The following is a description of a gene set: species: Homo sapiens Genes having at least one occurrence of the motif SNNGATNNNN in the regions spanning 4 kb centered on their transcription starting sites. This matches the GATA1 transcription factor binding site V$GATA1_01 (v7.4 TRANSFAC). Human Gene Set: GATA1_01, and this is the list of marker genes: MMEL1, TLN1, GABRA3, PPP2R2A, ZNF516-DT, CNOT3, ARRDC1-AS1, XRCC6, HCRT, SNCA (NCBI Gene Id 6622), DYRK1A, SP7, HOXB5, STX1B, DLG2, CARMIL3, TSPAN1, ZIC1 (NCBI Gene Id 7545), KIF1B, YWHAE, CACNG2, ERG28, PTK7, ELAVL2, HR, HOXA10, HOXD10, NAB2, TF, SDHAF2, CREB3, OXCT1, PPP2R2B (NCBI Gene Id 56686), CLU, GRIN3A, SUV39H1, IL17B, SLC4A3, MAK16, ACACA, AZIN1, C6orf62, SCML4, RERE, NELFB, SOX2, BAHD1, HIRA, PROX1, ATP2B2, RAB3C, NDUFAF3, CDC27, FHL3, WAC, MED26, TNXB, TOR1AIP1, RSF1, ABRAXAS2, TNPO3, TTC9B, ENSG00000204117, FRMD5, CCDC140, ING3, BMP7, CLVS1 (NCBI Gene Id 157807), JOSD2 (Josephin domain containing 2), MRPL40, CLTA, LSAMP, PCDH8, YARS1, IL17RE, HSPA14, PRDX5, FEZF2, IL21, RAPGEF6, PTCHD1, ZIC4 (NCBI Gene Id 84107), PMS2P5, MAPRE3, SYNCRIP, BLCAP, GNB1, SRSF6, HSPG2, KIF3B, ACLY, KPNB1, HHEX, UBE2D2, PENK, DPYSL2, NFYC, TRERF1, CPSF7, KCTD13, RARG, ACTN3, NR2E1, SIPA1, ANK3, SLC39A5, SLAIN1, TLE3, GRID2, FAM181B, SPACA6 (NCBI Gene Id 730718), SLC8A3, BNC2, RCN2, TMEM196, RASAL2, PHEX, ZFHX3, TCF7L1, TSPAN5, VCPKMT, AAMDC, NHLH2, INHA, DHX15, CXCR5, GDF6, KAT7, MOSMO (NCBI Gene Id 730593), SREBF2, AMMECR1, ZNF423, SPOP, SUFU, PYGO2, RPS6KB1, SRF, AKT2, MAML3, EPHB1, ARL5B, NFIA, ATXN7L2, ENPP2, ANKRD17 (NCBI Gene Id 84177), PILRB, HNRNPL, FAM131A, SPATA32, TOB2, CLN5, MAP3K3, POU3F1, ANGPT1, PLA2G2F, UBE2H, NXPH4, LHX1, SSTR3, KPNA4, PLXNC1, DALRD3, RCAN1, LRRC4, PDZD7, RPIA, TSSK3, RGL2, SP3, SOX12, ZSCAN18, PLK4, CTCF, SUPT16H, CPNE1, LINC00670, PHF12, LMOD1, LHX9, TPI1P2, POU2F1, POU3F4, VDAC2 (voltage dependent anion channel 2), NDST2, AKR7L, ZDHHC24 (NCBI Gene Id 254359), LMO3, ADD3, MAGED2, TRIM3, C12orf75, KLF2, OBI1, ZNF827, INHBE, R3HDM1, PDLIM4, ZMYM2, SOBP, NTRK3, NCDN, WNT5A, RAB10, GRIN2B, KCNB2, CLOCK (NCBI Gene Id 9575), PTP4A3, DOCK11, PAX3, LIN28A, GADD45A, RORA, OAZ2, RIT2, OARD1, CRLF1, HS3ST3B1, RBM5, TMEM97, LIPG, AEBP2, RBMX, RPS6KA3, GRIN2A, STAG2, DRD5, ZIC3, VEZF1, TRMT112, FEZ2, ZNF800, DOLPP1, KLHL34, MSH2, STAC2, DIXDC1, PPP1R21, LHX6, WDR53, IMMT, PHOX2B, CFAP65, LRP1, SALL1, ACTR1A, YBX1, LCOR